The following is a description of a gene set: Mouse Gene Set: GOBP_PROTEIN_IMPORT_INTO_MITOCHONDRIAL_INTERMEMBRANE_SPACE species: Mus musculus The import of proteins into the space between the inner and outer mitochondrial membranes., and this is the list of marker genes: Aifm1, AU015836, Hspd1 (heat shock protein 1 (chaperonin)), Chchd4, Gfer